Given this list of marker genes Gpr21, Ephb2, Thra, Mat2a, Rae1, Apobec1, Fam124a, Trpc4ap, Tpst2, Tspan11, Pcdhb16, Carmil1, Enc1, Dhx40, Trem3, Cntd1, Cdc42, Fktn, Tspan18, Csnk2a1, Plxna4, Alyreffm14, Grhl2, Plekhh1, Pcdha11, Glod5, Tecr, Nol6, Ccdc174, Sox13, Nucb2, Eif4h, Gpr156, Rheb, Coro2b, Tcf12, Zup1, Pcdhac1, Hipk1, Zfp142, Phlpp2, Rapgef3, Mup3, Nr1d1, Xylt2, Ctla4, Slc24a2, Svs3b, Ppp6r1, Tmem41a, Crtac1, Gdf5, Arl8b, Slc4a5, Grb2, Fbxl17, Cbfa2t3, Tnrc6b, Synm, Alyreffm10, Wnt7a, Phldb1, Trappc2, Flot2, Coro1c, Zxdb, Car10, Pcdhac2, Csmd2, Alyreffm16, Pth, Kcne1, Adam12, Hic2, Robo2, Pcdha2, Celf2, Ark2c, Adam22 (NCBI Gene Id 72849), Ralgapb, Pcdha7, Arhgef9, Dcaf17, Rock2, Itsn1, Ocln, Dlg2, Map4k4, Ano5, Dnase1l3, Alyreffm17, Igf1r, Cyyr1, Phactr2, Slc9a1, Cfl2, Alyreffm13, Otof, Syndig1l, Rhot1, Pcdha10, Csf3, Slc8a1, Ssu72, Brpf3, Cgn, Slc7a1, Pcdh10, Dynll2, Mier1, Arl4a, Ube2d2b (NCBI Gene Id 73318), Ankfy1, Tox3 (NCBI Gene Id 244579), Heyl, Usp3, Rab3d, Galnt17, Krtap5-5, Dcaf8l, Ikbkg, 1700019A02Rik, Atp1a3, Eya3, Tmed5, Zfp157, Bcat1, Smg7, Tead1, Tmco5b, Fgf14, Pcdha5, Pcdha4, Dgkk, Pcdha3, Pcdha1, Zmym3, Rab27b, Rprd2, Adgrb1, Pcna, Slc16a2, Rbfox2, Ntrk2, Sgms1, Slc4a8 (NCBI Gene Id 59033), Elp4, Sez6l2, Apba1, Rere, Zcchc14, Fchsd2, Creb3l2, Notch2, Cldn23, Anxa2 (annexin A2), Dusp15, Dars1, Hsf5, Six3, Pcdha12, Cnot9, Kif1b (NCBI Gene Id 16561), Adam2, Rnf20, Alyreffm11, Zfp385a, Zmpste24, Clstn1, Syn1, Plekhb1, Zfp938, Ppp2r1b, Rad54l2, Slc41a1, Pip5k1c, Igf1, Agap1, Klhl34, Gsk3b, Grem2, Ago1, Idua, Pcdha6, Cpeb3, Hook3, Rit2, Rora, 4921536K21Rik, Alyreffm15, Pcdha9, Pak2, Cdyl2, Zscan20, Magi2 (NCBI Gene Id 50791), G6pc1 (glucose-6-phosphatase catalytic subunit 1), Plekhg4, Klk5, St6galnac3, Eps8l1, Srgap2, here is a description of the gene set: from publication Chen Y, Wang X (PMID 31504780) studied in species Mus musculus Genes predicted to be targets of miRBase v22 microRNA mmu_miR_3473a in miRDB v6.0 with MirTarget v4 prediction scores > 80 (high confidence targets). Mouse Gene Set: MIR_3473A